The following is a description of a gene set: Reactome Pathway: Autointegration results in viral DNA circles part of: Integration of provirus species: Homo sapiens In this pathway, the viral integration machinery uses a site within the viral DNA as an integration target. This results in a covalent rearrangment of the viral DNA. The resulting DNA forms are not substrates for integration.<br>It has been suggested that the cellular BAF protein binds to viral DNA and diminishes autointegration by coating and condensing the viral DNA, thereby making it a less efficient integration target.<br>, and this is the list of marker genes: HMGA1, BANF1, PSIP1, rev, vpr, vpu, vif, gag, gag-pol